Given this list of marker genes NOTCH2, SATB2, TRIM35, NUMBL, LOXL3, LRRC55, COPS7B, MPP2, AKAP1, STRN3, SYT4, SEMA5B, ARHGAP1, SLC2A4RG, CAPN6, FAM167A, STAC2, SBK1, SP2, SHKBP1, RAB11FIP4, RNF4, VAT1, LEF1, DCX, KIAA1217, TFDP2, TBC1D25, C1orf116, FAM76A, POGZ, LGR4, ATG4B, PLPPR2, CACNB1, TPD52, STC1 (stanniocalcin 1), MAPT, ARHGAP26, SNX15, AP2S1, SYVN1, ELMOD1, MET, CASP2 (caspase 2), PDGFRA, METAP1, JAG1, PNOC, FGD6, TNRC6B, DPYSL4, PGM1, HCN3, MGAT5B, MGAT4A, APH1A, TTC19, KLF12, ZNF207, PURB, TMEM184B, GLCE, MAP2K1, B3GAT3 (beta-1,3-glucuronyltransferase 3), SYNJ1, KLF4, NCEH1 (neutral cholesterol ester hydrolase 1), KCNH2, DPP3, GPR85, CA7, SEPTIN3, ZER1, RRAS, SCN2B, UBP1, MAP1A, CBFA2T3, OTX1, CSF1R, ZDHHC17, PPP2R5A, ACSL4, SLC2A13, GDAP1L1, TMEM255A, NETO1, AKAP6, FOXP1, ZNF644, RGS17, SEMA4C, AHCYL2, KYAT1, TMCC3, FIGN, SATB1, ZNF282, FOXJ2, SGSM2, AMER1, CDK6, ABTB3, PPP1R16B, VAMP2, PPFIA1 (PTPRF interacting protein alpha 1), TAF5, WNT1, VCL, DMAC2L (distal membrane arm assembly component 2 like), PLOD1, DIXDC1, VEZT, EML5, RALGPS2, CAMTA1, SVOP, CNTN2, PTPRM, RNF41, OSGIN2, SIDT1, ERGIC1, PKIA, CUEDC1, XPO5, VEGFA, NAV3, LIMD2, PPP1R14D (protein phosphatase 1 regulatory inhibitor subunit 14D), RIMS4, STK35, RALGDS, PPP1R11, CACNB3, TGIF2, CORO1C, ACSL1, ALDOA, SGPP1, MEX3C, SOX4, CNTNAP1, ABR, CNOT6 (NCBI Gene Id 60404), SEC61A1, TCF12, KITLG, HTR2C (5-hydroxytryptamine receptor 2C), PIP4P2, MLLT3, RAB5IF, GMFB, HYCC2, DGKZ, MYRIP, SPRN, NAA50, ATXN2L, SAR1A, ANK2, NRXN2, CNOT4, GRK6, CELF3, ZNF281, MSL2, PKP4 (plakophilin 4), SEMA4F, RTN4RL1, AGO4, ARID4B, ZBTB39, PPP2R3A, ALCAM, BCL6, TBL1XR1, F2RL2, RARG, E2F3, BCL9L, CSNK1G3, CRHR1, E2F5, RANBP10, NTNG2, SYT1, ZDHHC23, CTNND2, GRM7, SPEG, MTA2, ASB1, FNDC8, ABCF3, FUT8, KRT40, BRINP1, AXL (AXL receptor tyrosine kinase), GPHB5, NFE2L1, SLCO3A1, WSCD2, NAV1, PPP1CC, LDHA, ZMYM4, SUCO, RAB43, JAKMIP1, TMEM109, IQGAP3, ZFHX4, PACS1, FOXG1, CALCR, NR4A2, SNW1, PPP1R10, LYST, ZNF3, ITSN1, POFUT1, NOTCH1, ACTR1A, PEA15, TMUB2, ADGRL1, EI24, SDHC, DDX17, NSUN5P2, ASIC2, ZC3H7B, WASF1, GALT, ADGRG2, BEST1, RIC8B, DLL1, SERPINE1, SRPRA, CCNE2, XYLT1, CPLX2, NPTX1, ILKAP, PLEKHG5, PLCB1, EVI5L, TOB2, CELF2, FRMD4A, MIDEAS, CPEB3, BAZ2A, DAAM1, DNAJC16 (NCBI Gene Id 23341), ESRRA, LZTS3 (leucine zipper tumor suppressor family member 3), CHMP7, SPRY3, B4GALT2, LMAN2L, BRPF3, ZCCHC17, CREB5, C14orf28, SLC44A2, GRID1, RPS6KA4, SEMA4B, NRIP3, MARCHF5, SHISA7, ACBD3, CSNK1G1, CNTNAP2, UHRF2, COL12A1, here is a description of the gene set: Genes having at least one occurence of the motif CACTGCC in their 3' untranslated region. The motif represents putative target (that is, seed match) of human mature miRNAs hsa-miR-34a, hsa-miR-34c and hsa-miR-449 (v7.1 miRBase). Human Gene Set: CACTGCC_MIR34A_MIR34C_MIR449 studied in species Homo sapiens